Given this list of marker genes Uba52rt, Egln3, Egln1, Psmd11, Ubc, Ube2d2a, Psma7, Ep300, Limd1, Ajuba, Psmb6, Psmd8, Arnt, Psmc2, Psmc6, Ube2d3, Psmb3, Elob, Psmb4, Psmd13 (NCBI Gene Id 23997), Psmc5, Cited2, Rbx1, Psmd3, Psmd14, Psmd12, Psmd1, Psmc1, Psmb2, Psmc4, Hif1a, Rps27a, Psma2, Ubb, Cul2, Psma5, Psmc3, Ube2d1, Epas1, Psmb1, Adrm1, Eloc, Wtip, Psmb7, Psma6, Psmb5, Psma3, Psma1, Uba52, Psmd6, Psmd7, Psmd2, Hif3a, Vhl, Psma4, Egln2, Hif1an, here is a description of the gene set: Mouse Gene Set: REACTOME_CELLULAR_RESPONSE_TO_HYPOXIA studied in species Mus musculus Cellular response to hypoxia